Given this list of marker genes OFD1, FAM149B1, TMEM231, TOPORS, NEK1, RBM10, KIAA0753, KIF7, CPLANE1, PDE6D, TCTN3, SCNM1, TMEM216, ECM1, PRKAR1A, PDE11A, here is a description of the gene set: Tongue nodules Human Gene Set: HP_TONGUE_NODULES species: Homo sapiens